The following is a description of a gene set: studied in species Homo sapiens Human Gene Set: AP1_C Genes having at least one occurrence of the motif NTGASTCAG in the regions spanning 4 kb centered on their transcription starting sites. This matches the JUN transcription factor binding site V$AP1_C (v7.4 TRANSFAC)., and this is the list of marker genes: PDGFRB (platelet derived growth factor receptor beta), ANKRD22, DTNA, LAMC1, PPP1R9B, PCDH9, PITPNC1, PHLDB3, YIF1A, CLIC1, CNTF, FBXO2, EPHB2, TLL1, EML3, SNCB, GSE1, SLC26A1, DYRK1A, SKIDA1, EWSR1, ATXN7L2, VEGFD, RIN1, ASB5, ADAM15, GADD45A, ZNF771, GKN1, PLCD1, ZNF385B, PACSIN3, BTG3, CLDN17, VCL, SNX10, RCAN2, CA9, SYNGR1, CYTOR, GADD45G, XPOT, PCYT2, CNTD1, PPP2CA, CSF3, PLEKHA5, RIT1, ADRA1A, TCF7, HSPB8, POLR3E, WNT6, SLC22A18, SHC3, CPNE8, CLDN15, UBE2E3, RELA, NTN4, LAPTM5, SCEL, MIDEAS, HOXA11, TLX2, ATP6V1B2, MYB, EYA1, PLEKHH3, FBXW11, SMARCA2, COQ8B, RGS2, VASP, CAPN6 (calpain 6), MDFI, BUD31, USP13, EFNA1, ANK3, RHBDD3, CSMD3, MCF2, SH3RF2, CALB2, TUBA4A, IQSEC1, ROM1, EPHA2, ABCD1, TIAL1, ABHD4, SEPTIN4, CXCR5, SLC16A6, COL7A1, LINC02908, CPA6, ABCF3, LYSMD2 (LysM domain containing 2), PLEC, FOSL1, XIRP1, C15orf39, FAM81A, ATP6V1C2, FRMD5, PEA15, NECAB3, MYBPH, DIRAS1 (NCBI Gene Id 148252), PALS1, TMEM54, CRYBA2, NFRKB, MAMDC2, FGF11 (fibroblast growth factor 11), FSTL1, ITPKC, RAB3D, LYVE1, HS3ST2, VAT1, AP2M1 (NCBI Gene Id 1173), VDR, MARK1, PPP1R15A, SNCG, GJA1, PKN3, TUBB4A, NOTCH4, ESRRG, SLC38A3, KDM3A, MAP1A, PRX (NCBI Gene Id 57716), OMG, CD68, WDFY3, PSMD1, SLCO5A1, SPRED1, SFN, FBXO44, MET, XYLT1, MLEC, NDP, IL11, LORICRIN, MSI1, ZNF207, TTC1, SERPINB5, TBC1D17, ELAVL2, BACH1, MAP2, PRR7, SYT2, TEX19, SLC4A11, CHST4, HSPB6, SYTL1, SLC35B1, RPS6KA4, AQP5, TSR1, FABP4, MNT, ZNF516-DT, NEFH, PSME4, CLSTN3, SLITRK6, FAM184A, RAP1GAP2, COL16A1, KCNH6, IRAK1, MAP4, CDH23, MYOZ2, HCN3, LAMA3, VIT, SV2B, WDFY3-AS2, BTK, FLNC, NUDT10, EPB41L1, SSH2, TRPV3, ETV5, CAPN12, ARAP2, RBBP7, RNF34, IL9, EPHA1, HDAC3, ULK1, NUAK1, BLMH, LAMC2, LTBP3, VAPA, AIG1, MAPRE3, PPP2CB, MMP9, TOB1, GRIA1, SDCBP, DTX2, NUDT11, ATP1B1, RBP4, FGF9, GABARAPL1, PHLDA2, FERMT3 (FERM domain containing kindlin 3), RTN3 (NCBI Gene Id 95608), S100A5, CTTNBP2NL, WNT7B, FBRS, REEP4, HEPH, ARHGAP32, C19orf33, STAT5B, PROCR, ROCK2, EMP1, TYSND1, KLHL40, RP1L1 (NCBI Gene Id 94137), PTPRR, RB1CC1, RNF144B, TRAPPC3, PIANP, SFTPC, BAZ2A, SLC25A51, GDNF, USP2, IDS, CALCOCO1, LENEP, CCDC120, LMNA, IVL, LRRN4CL, SMPX, MARK4, CCDC50, UBALD1, RHBDF1, IL10, REXO2, CMAS, USP3, ZFAND5, PROSER3, SEMA3B, LPP, PRDM1, LRRFIP2, ZFYVE9, POLD4, SEC24D (NCBI Gene Id 9871), HSPB7